The following is a description of a gene set: Human Gene Set: HP_BROAD_PALM Broad palm studied in species Homo sapiens For children from birth to 4 years of age the palm width is more than 2 SD above the mean; for children from 4 to 16 years of age the palm width is above the 95th centile; or, the width of the palm appears disproportionately wide for the length., and this is the list of marker genes: PIK3CA, GNS, BCOR, DYNC1H1, FBN1, LBR, TBL1XR1, ASXL1, GPC4, PTH1R, FGFR1, FHL1, PRKAR1A, COL2A1 (NCBI Gene Id 444981), DEAF1, TONSL, DYM, RAI1, KDM6B, DLG5, FLII, AIFM1 (NCBI Gene Id 9131), PIGA, DHX30, IFT80 (NCBI Gene Id 57560), GPC3, ADAMTS10, FGD1, SLC35C1, SPECC1L, PPP2R3C, RPS6KA3, TOMM7, IHH, B3GLCT, DDR2, IQSEC2, CTCF, SRRM2